Given this list of marker genes FKRP, BHLHA15, LARGE1, CD2AP, SLC48A1, POMGNT1, here is a description of the gene set: Any process in which a cell is transported to, and/or maintained in, a specific location. Human Gene Set: GOBP_LOCALIZATION_OF_CELL species: Homo sapiens